The following is a description of a gene set: species: Homo sapiens from publication Amit I, Citri A, Shay T, Lu Y, Katz M, Zhang F, Tarcic G, Siwak D, Lahad J, Jacob-Hirsch J, Amariglio N, Vaisman N, Segal E, Rechavi G, Alon U, Mills GB, Domany E, Yarden Y (PMID 17322878) Genes whose expression peaked at 480 min after stimulation of MCF10A cells with serum. Signaling pathways invoke interplays between forward signaling and feedback to drive robust cellular response. In this study, we address the dynamics of growth factor signaling through profiling of protein phosphorylation and gene expression, demonstrating the presence of a kinetically defined cluster of delayed early genes that function to attenuate the early events of growth factor signaling. Using epidermal growth factor receptor signaling as the major model system and concentrating on regulation of transcription and mRNA stability, we demonstrate that a number of genes within the delayed early gene cluster function as feedback regulators of immediate early genes. Consistent with their role in negative regulation of cell signaling, genes within this cluster are downregulated in diverse tumor types, in correlation with clinical outcome. More generally, our study proposes a mechanistic description of the cellular response to growth factors by defining architectural motifs that underlie the function of signaling networks. Human Gene Set: AMIT_SERUM_RESPONSE_480_MCF10A, and this is the list of marker genes: MT1F, MOB3B, SPRR1B, ZBTB24, GMEB2, MRGBP, NSMF, POLR1G, MALL, PARG, CD24, SPRR2A, SLC25A32, COPS8, HSPBP1, MCM10, SIGMAR1, KRT10, ACTBP9, CDV3, PVR, CYB5R1, TIMM23, SLC26A2, MFAP5, SSNA1, FOSL1, TPM1, OR7E12P, ADGRG2, MRM2, B4GALT4, COX10, ACTN4, KRT6A, APIP, S100P, PTX3, SPRR1A